The following is a description of a gene set: Ageing of the brain leads to impairments in cognitive and motor skills, and is the major risk factor for several common neurological disorders such as Alzheimer disease (AD) and Parkinson disease (PD). Recent studies suggest that normal brain ageing is associated with subtle morphological and functional alterations in specific neuronal circuits, as opposed to large-scale neuronal loss. In fact, ageing of the central nervous system in diverse mammalian species shares many features, such as atrophy of pyramidal neurons, synaptic atrophy, decrease of striatal dopamine receptors, accumulation of fluorescent pigments, cytoskeletal abnormalities, and reactive astrocytes and microglia. To provide the first global analysis of brain ageing at the molecular level, we used oligonucleotide arrays representing genes to determine the gene-expression profile of the ageing neocortex and cerebellum in mice. Ageing resulted in a gene-expression profile indicative of an inflammatory response, oxidative stress and reduced neurotrophic support in both brain regions. At the transcriptional level, brain ageing in mice displays parallels with human neurodegenerative disorders. Caloric restriction, which retards the ageing process in mammals, selectively attenuated the age-associated induction of genes encoding inflammatory and stress responses. Upregulated in the neocortex of aged adult mice (30-month) vs young adult (5-month) studied in species Mus musculus from publication Lee CK, Weindruch R, Prolla TA (PMID 10888876) Human Gene Set: LEE_AGING_NEOCORTEX_UP, and this is the list of marker genes: VIM, PSAT1, SPP1, SEC23B, MAG (myelin associated glycoprotein), JUNB, CTSS, RUFY1, P4HA1, DHX15, RRAGA, AKT2, AVP, VEGFA, CYB561 (cytochrome b561), CTSZ, SEMA4B, SET, M6PR, CTNNB1, COX8BP (NCBI Gene Id 404544), GFAP, VPS72 (vacuolar protein sorting 72 homolog), NR4A1, TUBB (tubulin beta class I), APOD, CMPK1, VAMP1, FOS, ITIH3, LCAT, FXYD6, PTGS1, OXT, ATP1B3 (NCBI Gene Id 483), NDRG1, LGALS3BP, STOM, B2M (NCBI Gene Id 567), IFI27, CTSD, DNAJA4, MYL12A, CRYAB, STXBP3, CSNK1G2, NUB1, PPP1R2, C1QA, ICAM2, SAT1, CD9, MPEG1, GADD45A, EEF2, RAB4A, RHOG, DDIT3, DLG1, LAMB1, KCNA1, ALDOC, CD68, RAB14, WWOX, CSNK1D, UBC, NAPA, DNAH8, S100A10, PHB1, CCL21, PPP2R5C, C1QC, C4B, HSD17B12, DNAJB13